The following is a description of a gene set: Human Gene Set: DHIMAN_PBMC_ATTENUVAX_AGE_15_25YO_SUBQ_7_OR_14DY_UP from publication Dhiman N, Ovsyannikova IG, Oberg AL, Grill DE, Jacobson RM, Poland GA (PMID 16571413) Cellular immunity to measles vaccination is not fully understood at the effector response and gene expression levels. We enrolled 15 healthy individuals (15-25 years old) previously vaccinated with two doses of measles-mumps-rubella-II vaccine to characterize their cellular immunity. We detected a spectrum of lymphoproliferative response (median stimulation indices of 3.4), low precursor frequencies of interferon-gamma (median 0.11%) and interleukin-4 (median 0.05%) by Elispot, and cosecretion of Th1 and Th2 cytokines after measles virus stimulation. Further, global gene expression was examined in five subjects from this cohort after vaccination with an additional dose of measles vaccine (Attenuax, Merck) to identify the genes involved in measles immunity. Linear mixed effect models were used to identify genes significantly up or downregulated in vivo between baseline and Days 7 and 14 after measles vaccination. Measles vaccination induced upregulation of a set of genes, which play a role in measles immunity, signal transduction, apoptosis, cell proliferation, and metabolic pathways. Among the genes that were downregulated, only interferon-alpha is known to have a direct role in measles immunity. This study suggests that measles vaccination leads to activation of multiple cellular mechanisms that can override the immunosuppressant effects of the measles virus and induce immunity. Genes up-regulated in peripheral blood mononuclear cell 7d or 14d vs 0d in adults (15-25) after exposure to Attenuvax, time point 7 or 14D, administered subcutaneous studied in species Homo sapiens, and this is the list of marker genes: UNC119, PSMD3, CIITA, SLC11A2, ZNF710-AS1, EPM2AIP1, PROCR, MAGEC1, YES1, GATA3, TST, KLK11, EEA1, UBE2N, RPGRIP1L, ADAM9, CKMT2, F2R, NPY6R, SGK1, UPK1A, MATN3, MTCL2, SPRR2A, SPIN2A, GIGYF2, PLK4, PIGL, BBC3, ABCG1, SLC19A1, ZSCAN12, PFN1, SMARCD2, S1PR1, PLS3, BCAS2, MAGI1, DARS1, RYR2, ASCL1, RNASE1, UBE2V2, HNRNPAB, ATF2, FCHO1, SRSF8, ASPA, COL8A1 (collagen type VIII alpha 1 chain), ITGB1BP1, COBL